Given this list of marker genes TNF, C2CD4A, IL31RA, DNASE1, F2, DNASE1L3, ADAM8, MIR92A1, ADORA1, TRPV1, SCN11A, OSM, PTGES, PLSCR1, ELANE, PARK7, CCR7, OSMR, IL6, AHSG, IGHE, SAA2, EXT1, C3, HLA-E, FCGR3A, ORM2, EDNRB, PRCP, IL6R, FCER1A, F12, IGHG1, ANO6, FCER1G, FCGR3B, APCS, CEBPB, ACVR1, CD6 (NCBI Gene Id 923), LCN2, EPO, APOL2, REG3G, IL1RN, FFAR3 (NCBI Gene Id 2865), TNFRSF11A, RHBDD3, NLRP6, FFAR2, F8, FCGR2A, PTGS2, IL20RB, ASS1, MIR302E, LIPA, IL6ST, SAA1, ITIH4, TFRC, PIK3CG, MRGPRX1, IL22, STAT3, ORM1, CRP, GATA3, HP, TNFSF11, VNN1, TAC1, SERPINA3, CD163, CTNNBIP1, BTK, IL1A, FCGR2C, C2CD4B, B4GALT1, FCGR2B, INS, TNFSF4, SIGIRR, SERPINF2, FCGR1BP, NPFF (neuropeptide FF-amide peptide precursor), ZP3, ASH1L, NUPR1, NPY5R, PLA2G2D, SELENOS, MBL2, EIF2AK1, GSTP1, NLRP3, LBP, SAA4, F3, SPN, FN1, SERPINA1, IL1B, NPY, CREB3L3, FUT7, REG3A, KLKB1, CEBPA, PTGER3, FCGR1A, here is a description of the gene set: Human Gene Set: GOBP_ACUTE_INFLAMMATORY_RESPONSE studied in species Homo sapiens Inflammation which comprises a rapid, short-lived, relatively uniform response to acute injury or antigenic challenge and is characterized by accumulations of fluid, plasma proteins, and granulocytic leukocytes. An acute inflammatory response occurs within a matter of minutes or hours, and either resolves within a few days or becomes a chronic inflammatory response.